The following is a description of a gene set: The chemical reactions and pathways resulting in the formation of dTMP, deoxyribosylthymine monophosphate (2'-deoxyribosylthymine 5'-phosphate). studied in species Mus musculus Mouse Gene Set: GOBP_DTMP_BIOSYNTHETIC_PROCESS, and this is the list of marker genes: Dhfr, Shmt1, Tyms, Nme3, Shmt2, Dctd, Nme1, Dut (NCBI Gene Id 93804), Nme2